Given this list of marker genes Oas1a, Oas3, Lilrb4a (NCBI Gene Id 14728), Oas1g, Oas1f, Oas1d, Oas1h, Oas1e, Oas1b, Oas1c, Mavs, Lilrb4b, here is a description of the gene set: The appearance of IP-10 due to biosynthesis or secretion following a cellular stimulus, resulting in an increase in its intracellular or extracellular levels. Mouse Gene Set: GOBP_IP_10_PRODUCTION studied in species Mus musculus